The following is a description of a gene set: Neighborhood of RFC4 replication factor C (activator 1) 4, 37kDa in the GNF2 expression compendium Human Gene Set: GNF2_RFC4 Neighborhood of RFC4 species: Homo sapiens, and this is the list of marker genes: CDK1, NDC80, H2AZ1, FANCI, TOP2A, MSH2, BIRC5, RRM1, RPA3, CCNA2, SNRPD1, CCT2, SMC4, RFC4, TYMS, GINS1, RANBP1, TTK, CKS1B, MCM3, KIF11 (NCBI Gene Id 3832), MSH6, DKC1, KNTC1, FOXM1, ZWINT, UBE2C, RAD51AP1, LIG1, SSRP1, ITGB3BP (integrin subunit beta 3 binding protein), MCM4, SLBP, MCM2, MCM7, CCNB2, NCAPD2, MCM6, SUPT16H, PCLAF, MCM10, FEN1, SNRPE, PLK4, PCNA, RFC3, RAN, CKS2, TIMELESS, RFC5, CTPS1, PAICS (NCBI Gene Id 647765), GINS2, SMC2, ASPM, RAD54L, CENPF, GMNN, PRIM1, MLH1